Given this list of marker genes RNU4ATAC, RPS15A, ADAMTS10, RECQL4, RPL26, FGF10, SLC26A2, KCNH1, RPL18, UBE2T, TAF6, ROBO1, PSMD12 (NCBI Gene Id 5718), RPL35, HDAC8, FLNA, HEATR3, FANCE, ADA2 (adenosine deaminase 2), LRP4, TRPM3, ERI1, DHODH, RPL11, TFAP2A, BCOR, SALL4 (spalt like transcription factor 4), MED12, ZNF699, KDM1A, HOXA13, PTCH1, RTL1, FZD2, RAD51C, LMNB2, RPL9, EP300, RPS29, BICRA (NCBI Gene Id 29998), LAMA5 (laminin subunit alpha 5), FANCF, RAD21, SMC3, FGFR3, LTBP2, CREBBP, RPL35A, NOG, RPS20, RPS27, FANCA, GDF5, FGFRL1, GNAS, NIPBL, RPS7, PALB2, FANCI, RPS17, SVBP, CANT1 (calcium activated nucleotidase 1), LETM1, ATP6V1B2, RPS24 (ribosomal protein S24), SETBP1, IHH (Indian hedgehog signaling molecule), RPS26, RPS10, PIK3CD, MIR17HG, BRCA2, MAP3K7, FGFR1, TSR2, BRIP1, ACAN, RBM8A, WIPI2, CHD7, SLX4, FIG4, GATA1, PKDCC, RPS28, MYCN, CTBP1, APC, ZMYM2, ESCO2, DHCR7, FANCD2, RIPK4, NELFA, ACVR1, RPS19, BMPR1B, BHLHA9, EIF4A3, RPL27, SRCAP (NCBI Gene Id 10847), RPL15, VPS35L, FGFR2, MEG3, COL2A1, KNSTRN, FBN1, MGP, SF3B4, RPL8, RPL31, FANCC (FA complementation group C), DLK1, ADAMTS17, NSD2, SOX9, PIGG, SMC1A, RPL5, CPLX1, BRD4 (bromodomain containing 4), TBX5, SIN3A, CHST11, PCNT, here is a description of the gene set: Human Gene Set: HP_SHORT_THUMB species: Homo sapiens Hypoplasia (congenital reduction in size) of the thumb. Short thumb